The following is a description of a gene set: Human Gene Set: GSE8685_IL15_ACT_IL2_STARVED_VS_IL21_ACT_IL2_STARVED_CD4_TCELL_UP from publication Marzec M, Halasa K, Kasprzycka M, Wysocka M, Liu X, Tobias JW, Baldwin D, Zhang Q, Odum N, Rook AH, Wasik MA (PMID 18281483) In this study we compared the effects of IL-2, IL-15, and IL-21 on the gene expression, activation of cell signaling pathways, and functional properties of cells derived from the CD4+ cutaneous T-cell lymphoma (CTCL). Whereas both IL-2 and IL-15 that signal through receptors that share the common gamma chain and the beta chain modulated the expression of >genes, IL-21 that signals via the receptor also containing gamma chain up-regulated <genes. All three cytokines induced tyrosine phosphorylation of Jak1 and Jak3. However, only IL-2 and IL-15 strongly activated STAT5, PI3K/Akt, and MEK/ERK signaling pathways. In contrast, IL-21 selectively activated STAT3. Whereas all three cytokines protected CTCL cells from apoptosis, only IL-2 and IL-15 promoted their proliferation. The effects of the cytokine stimulation were Jak3- and Jak1-kinase dependent. These findings document the vastly different impact of IL-2 and IL-15 vs. IL-21 on malignant CD4+ T cells. They also suggest two novel therapeutic approaches to CTCL and, possibly, other CD4+ T cell lymphomas: inhibition of the Jak1/Jak3 kinase complex and, given the known strong immunostimulatory properties of IL-21 on CD8+ T, NK, and B cells, application of this cytokine to boost an immune response against malignant CD4+ T cells. studied in species Homo sapiens Genes up-regulated in Sez-2 cells (T cell lymphoma): IL15 versus IL21., and this is the list of marker genes: TMBIM4, LBH, TREX1, POU2F1, CAST, PTPN9, ZNF106, TMEM65, TMTC4, KRT79, DPY19L3, FAM110A, UBL3, PER1 (period circadian regulator 1), GNG12, NPHP3, NUF2, STARD10, CCDC50, PLP2, GNG2, PTGDR, MARCHF3, NR4A1 (NCBI Gene Id 93352), ZFYVE19, SWAP70, CDK19, EGR2, FAM169BP, ALMS1, H1-1, IFITM3, STAT5B, GPR55, RLN3, RAB11FIP1, CYTH3, HCLS1, DNMT3A, NEK7, CENPE, HERPUD1, ARHGAP25, TLCD2, RBM45, STX16, MMP12, SFXN3, PLA2G4F, NHLRC2, TRIM14, GRTP1, DECR1, AP3B1, SSH1, SERINC5, CD274, CD27, KIF4A, SEMA4D, CCDC38, EPCAM, P4HA1, ATG2A, NFATC2, ATP2B1, MIR383, MPRIP, CC2D2B, VPS13C, SYNJ2, GFPT2, MYBPC3, MPP1, ESM1, GRHL1, TOP2A, PPT1, KTN1, GMCL1, VPS54, IFT80, TMEM212, CTXN1, SDC4, SCUBE1, IL17F, IL10RB, SLC43A1, RGS13, NLGN2, GREB1, N4BP1 (NEDD4 binding protein 1), CHEK2, SIGIRR, IRAK2, APLP2, SLC35F2, FRMD5, TRIB1, MDFIC (MyoD family inhibitor domain containing), GEMIN8, SYCN, PBX2, ELL2, VAV3, NEU3, SLC25A13, PLA2G15, DIO2, LCA5, LHFPL1, CYBB, AHI1, PPP1R3B, MIR217, CDCA8, SYNGR2, ARHGAP11A, BPIFB3, RYR2, TIGIT, SLC4A8, ABI1, GOT1, MSI2 (musashi RNA binding protein 2), TSPAN32, PCYT1B, DYNLRB1, GPR107, DLL4 (NCBI Gene Id 54567), CYTH4, AGPAT4, B3GNT2, AHCYL2, EDEM2, ACTG1, AGL, PLPP1, PHLPP1, GZMB, DGKZ, SH3BGRL, SH3BGRL2, ASXL1, MTMR3, KCNA3, S100A4, RNF135, DCC, SOCS5, DYNC2H1, POU2F2, RHOU, ANXA2, TOGARAM2, INPP5K, MFSD1, EIF4E3, RAB27A, RGS3, FCHO1, AKAP7, TSPAN3, TMEM67